The following is a description of a gene set: Human Gene Set: GOBP_DENDRITIC_CELL_DIFFERENTIATION The process in which a precursor cell type acquires the specialized features of a dendritic cell. A dendritic cell is a leukocyte of dendritic lineage specialized in the uptake, processing, and transport of antigens to lymph nodes for the purpose of stimulating an immune response via T cell activation. species: Homo sapiens, and this is the list of marker genes: TMEM176A, CCR7, ITGB6, TREM2, FLT3LG, GATA1, HLA-B, IL4, DCSTAMP, LILRB1, LYN, UBD, LGALS1, CLEC12A, AGER, RBPJ, F2RL1, CAMK4, TMEM176B, PSEN1, AZI2, IRF4, TRAF6, LILRB2, PRTN3, IRF8 (interferon regulatory factor 8), TGFBR2, MIR223, HMGB1 (high mobility group box 1), FCGR2B, CSF2, GAS6, TGFB1, LGALS9, ITGB8, BATF (basic leucine zipper ATF-like transcription factor), BATF2, LGALS3, TAOK3, CEBPB, BATF3, NOTCH2, CCL19 (NCBI Gene Id 6363), SPI1, TRPM2, FLT3, DHRS2, LTBR, AXL, ZBTB46, HLA-G, RELB